Given this list of marker genes MIR5188, NELFB, PRKY, PFN2, IL12B, SOCS3 (NCBI Gene Id 9021), E2F3, REEP5, TNFAIP2, DOCK7, LINC01600, RFESD, NR4A1, EVA1C, SETD2, ACTB, NEMP2-DT, PPP3CB-AS1, NMNAT2, CA2, ZNF217, LINC03033, LINC01686, LSM14B, MAPK1IP1L, PTPA, EDC4, LONRF1, SEC11A, EFHD2-AS1, KCNH1-IT1, SLC25A45, RARA, PLXNA2, ETFA, MLYCD, CAPN2, TUBB4B, LINC01508, MBD6, LNPEP, PPP1R3C, NCOA2, KCTD10, SEMA6D, NFKBIA, CXCL2, CRB1, HR, PYGO2, FZD5, WHAMMP2, NOTUM, AVPI1, HIPK3 (NCBI Gene Id 10114), SAMD4A, NFIB, DRAIC, PPARG, PCAT6, IER3-AS1, AMOTL2, SSBP2, GOLGA1, WASL, DENND3, NFKB2, DPY19L4, IAH1, MOB4, TDRD7, THEM6, GDF15, LNCOC1, RGS2, SRRM2, PTMA, IGF2BP3, MET, PLAGL2, SHANK2, CCNL1, PCBP1, GEMIN7, S100A2, ZBTB37, MYC, PTPN11, CASTOR3P, RCOR3, STK35, IRAIN, ANKRD40, OSMR, SOCS3-DT, DRAM1, PIAS3, ZNF767P, MAN1A2, DOCK7-DT, CAPS2, RB1-DT, TAF5L, ATXN2-AS (NCBI Gene Id 102723619), PID1, IDH3A, SMAD3, LPGAT1-AS1, MED13L, DPP10, ISG20L2, HM13-AS1, MALAT1, SLC48A1, TOB1-AS1, DNAH2, CD55, SRC, CTDSP1, SMAD3-DT, PLEKHM3, SLC22A4, KAZALD1 (Kazal type serine peptidase inhibitor domain 1), RABGGTA, EFHD2 (NCBI Gene Id 79453), ETV4, PRELID2, TBL1XR1, IBA57, IL6ST, USP3, TMSB10, SMAD5, TAGLN2, ATXN2, VMP1, MIR193BHG (MIR193b-365a host gene), USP9X, OPN3, UBE3B, LINC00677, ENSG00000272195, UNC5A, IRS2, SKIDA1, GPAT3, DLEU2, RCOR1, TRIB1, IDH1-AS1, SERPINB1, DTNA, KIF21A, CHMP6, ENSG00000249738, FABP5P3, ABCC3, BCL9, EXD3, PDK4-AS1, CERS2, OSMR-DT, CCDC57, DPP10-AS1, EEIG2, NCOA3, AIFM2, RPL6, PXMP2, NR4A2 (nuclear receptor subfamily 4 group A member 2), PLD1, FAM241B, ARID5B, CDC42BPA, ENAH, RERE, SYNRG, TOB1 (NCBI Gene Id 10140), RUFY2, PVT1, DEDD, WASL-DT, PYCR2, ID1, CASC11, SLC25A6, TFAP4, CYP2E1, DTWD1, GUSBP18, SIK2, MTMR10, CD226, TPRA1, KMT2A, RSAD1, OTUD7B, CT70, JMJD4, SEMA3D, LMNB1, SREBF1, INTS15, UPF3A, GPRC5A, NFATC1, NOL4L, PSMD3, KCTD18, SAMD11, MEF2A, IER2, UPP1, STAU2-AS1, NFE2L2, ENO3, EIF2D, CLN6, H2BC26, PFN1, ZBTB38, PHKA2 (NCBI Gene Id 5256), LRFN4, SHARPIN, TRIB3, FNBP1L, PTPRG, B4GALT7, TMEM144, ISG20, ALG5 (ALG5 dolichyl-phosphate beta-glucosyltransferase), LPCAT3, LINC02289, CIB2, TMEM100, BOLA3-DT, COG2, SEMA3E, EP400, AP5S1, MAF1, SUZ12P1, KMT2C (lysine methyltransferase 2C), RHOBTB3, IBA57-DT, IRF2-DT, LINC02742, TMEM222, BHLHE40, MAN2C1, LMNB1-DT, MEMO1, CLTC, CFL1P1, CYREN, KIF9-AS1 (NCBI Gene Id 285352), SMAD6 (SMAD family member 6), LINC02846, UBC, PRKAR2B, TMEM37, RTRAF, PCBP1-AS1, CCDC88A, TSEN15 (NCBI Gene Id 92120), MARK4, NEMP2, SCAMP5, GNB2, IRF2BP2, PPP1R3E, UNC5B, CRTC3, PITPNC1, NOXA1, BOLA3, LGALS3, CD63, MAP2K3, NAMPT-AS1, KANK2, SET, TBL1X, TNFAIP3, CD63-AS1, FNBP1P1, LPGAT1, PRSS23, PTGR3, LINC00963, RPH3AL, GAS5, RHOT2, CA3-AS1, DDIT4, PYGO2-AS1, KCNH1, SDK1, CTBP2, PSMF1, IKBKG, CHML, METTL25B, RUVBL1, RNU6-304P, NSFL1C, LPIN1, PRKCH, NAMPT, ID2-AS1, URB2, AXL, POLE, ANKRD18DP, METTL21A, FAM227B, DUS1L, ARHGEF40, ANTKMT, GLP2R, GMFB, IGF1R, KCTD3, PBX1-AS1, POFUT1, SOCS5, MID1IP1-AS1, SLC1A4, SMG1P3, HECTD1, LINC02288, CD109-AS1, P4HA2, CPNE2-DT (CPNE2 divergent transcript), SRRM2-AS1, IL6ST-DT, IDH1, PPP2R5A, ATAD1, RHOBTB1, NR2F1, FRA10AC1, PIK3R1, EXOSC3, AKT3, FAM171A2, DUSP1, PACSIN3 (NCBI Gene Id 51165, protein kinase C and casein kinase substrate in neurons 3), NR0B1, SGO2, SNHG7, IRF2 (NCBI Gene Id 3660), ARL5A, SNHG28, CFAP20 (cilia and flagella associated protein 20), ZMIZ1, TBC1D13, NRG1, CBX3, AGTPBP1, DDX55, SNAP47, CD109, TPK1, KMT5B, SEMA4B, NCBP3, ERLIN1, KLF10 (KLF transcription factor 10), SLC7A5P2, PDE4D, BCL3, FAM98B, LNCATV, FLOT1, CDC73, SLC25A20 (solute carrier family 25 member 20), RB1, CTH, here is a description of the gene set: from publication Yevshin I, Sharipov R, Kolmykov S, Kondrakhin Y, Kolpakov F (PMID 30445619) Genes containing one or more binding sites for (NR0B1) in their promoter regions (TSS -1000,+100 bp) as identified by GTRD version 20.06 ChIP-seq harmonization. Human Gene Set: NR0B1_TARGET_GENES species: Homo sapiens